Given this list of marker genes Lhx8, Mbnl1, Pcdh9, Fhl4, Syt13, Fnip1, Atl2, Cyp2j12, Usp28, Mc4r, Tmem200c, Arl8b, Fsd1l, Osbpl9, Rictor, Rnf111, C9orf72, Gabrg1, Gpatch8, Cpne8, Lats2, Phf3, Selenot, Cracd, Zfp91, Ccnt2, Crkl, Arl2bp, Chrna9, Bcl2l13, Arhgap35, Zfp984, Zfp268, Rap2c, Or7a38, Wee2, Rspo3, Clk2, Nbea, Fubp3, Rbl1, Ap1s3, Zfp281, Rnf166 (NCBI Gene Id 68718), 4930550C14Rik, Dlg5, Sos1, Srsf7, Dcps, Fbxw7, H2-M2, Zfp202, Spred1 (sprouty protein with EVH-1 domain 1, related sequence), Ubr7, Klhl21, Tspan12, Dst, here is a description of the gene set: Genes predicted to be targets of miRBase v22 microRNA mmu_miR_188_5p in miRDB v6.0 with MirTarget v4 prediction scores > 80 (high confidence targets). from publication Chen Y, Wang X (PMID 31504780) Mouse Gene Set: MIR_188_5P species: Mus musculus